Given this list of marker genes KYNU, KISS1R, KCNJ10, DUSP6 (NCBI Gene Id 1848), PRPH2, MITF, KCNE1, MAP3K7, WDR11, ESRP1, KARS1, USH2A, IGF1, FGF8, COX16, FOXI1, TUBB2B, KIF21A, PRPS1, RAC1, PHOX2A, COL25A1, TACR3, SLC26A4, TUBA1A, TUBB3, GREB1L, ROR1, LRTOMT, MRPS7, WFS1, PROK2, GJB6, KISS1, HS6ST1, KITLG, GNRHR, PAX3, USH1C, TAC3, ADGRV1, FGFR1, SPRY4, EBF3, FGF17, GJB2, PCDH15, POU3F4, GNRH1, PROKR2, RDH5, PDZD7, RLBP1, NSMF, NHLH2, RHO, CHD7, KCNQ1, here is a description of the gene set: A type of hearing impairment caused by an abnormal functionality of the cochlear nerve with congenital onset. Human Gene Set: HP_CONGENITAL_SENSORINEURAL_HEARING_IMPAIRMENT species: Homo sapiens Congenital sensorineural hearing impairment